The following is a description of a gene set: species: Homo sapiens Human Gene Set: FOROUTAN_TGFB_EMT_DN Most cancer deaths are due to metastasis, and epithelial-to-mesenchymal transition (EMT) plays a central role in driving cancer cell metastasis. EMT is induced by different stimuli, leading to different signaling patterns and therapeutic responses. TGF_ is one of the best-studied drivers of EMT, and many drugs are available to target this signaling pathway. A comprehensive bioinformatics approach was employed to derive a signature for TGF_-induced EMT which can be used to score TGF_-driven EMT in cells and clinical specimens. Multiple datasets were used to derive the signature using three approaches: by integrating the datasets prior to identifying EMT genes, by first identifying EMT genes from individual datasets and then combining them using a meta-analysis (product of ranks) approach, and by combining inferences from the first two approaches. Genes down-regulated in the epithelial-mesenchymal transition (EMT) upon transforming growth factor beta (TGFb) stimulation derived from multiple datasets by combining results from an integrative approach and a product of ranks meta-analysis approach. from publication Foroutan M, Cursons J, Hediyeh-Zadeh S, Thompson EW, Davis MJ (PMID 28119430), and this is the list of marker genes: CD9, TMT1A, ELF3, MTUS1, MITF, GLDC, LSR, GPRC5C, GRTP1, ADORA2B, ABLIM1, AGR2, CFB, TBC1D8, SULT1A1, HOOK1, EPCAM, PLAAT4, CDH1, ERBB3, SOX2, RAB26 (RAB26, member RAS oncogene family), S100P, BIRC3, EPAS1, PLAAT3, CP, PPP1R9A, SLC16A7, DEPTOR, CEBPD, KITLG, EPB41L4B (erythrocyte membrane protein band 4.1 like 4B), SORD, VAV3, LCN2, C1orf115, SLPI, MMP7, MAP7, EMP1 (epithelial membrane protein 1), GSE1, HPGD, SMPDL3B, FOXA2, CITED2, ERMP1, RAB38, MPZL2, ARHGAP29, MYO5C, EREG, FGFBP1, ALDH3A2, RAB25, CYB5A, ALDH1A3, TMEM30B, IMPA2, LY6E, GDF15, AREG, TNFAIP2, PDK4 (NCBI Gene Id 5166), TSPAN1, SQOR, PKP2, DST, SYNE2, SLC27A2, PPL, JAG2, HS3ST1, MANSC1, ATP8B1, NUP210, TJP2, AQP3, CYP1B1 (cytochrome P450 family 1 subfamily B member 1), TFAP2A, ALDH5A1, KRT15, GULP1, CEACAM6, KRT19, CFH, SCNN1A, SYBU, INHBB, ANK3, RBM47, LAMA5, SPRY1, DEFB1, CAVIN2, PEG10, NR2F2, PLS1, CXADR, SERPINB1, MUC1, EHF, FA2H, C1orf116, MBP, TPD52L1, ESRP1, SLCO4A1